The following is a description of a gene set: studied in species Mus musculus from publication Chen Y, Wang X (PMID 31504780) Genes predicted to be targets of miRBase v22 microRNA mmu_miR_6924_5p in miRDB v6.0 with MirTarget v4 prediction scores > 80 (high confidence targets). Mouse Gene Set: MIR_6924_5P, and this is the list of marker genes: Runx1t1, Ucp2, Mex3c, Hmgn3, Ibsp, Nrk, Sema3a, Siglecl2, Ift74, Lyrm2, Rnf170, Slc6a17, Atn1, Fgf14, Syt1, Atp2b3, Tmem201, Lrrfip2, Sestd1, Prkg1, Pot1b, Eme2, Anapc10, Kmt2a, Cerk, Tspan33, Zc3h12d, Cyp11a1, Ces2g, Klrg1, Pou2f1, Txlng, Spata9 (NCBI Gene Id 77955), Xpo7 (exportin 7), Mpdu1, Clasp1, Cxcr6, Nrg3, B3gnt6, Baz2a, Trim40, Cd300lf, Asgr2, Zfp35, Mrrf, Agap1, Dsn1, Pou2f2, Mknk1, Septin6, Eml6, Rdh13, Nsd1, Egfr, Sprr1a, Sh2d4a, Nt5e, Slc25a36, Cyp3a13